The following is a description of a gene set: from publication Cui A, Huang T, Li S, Ma A, Pérez JL, Sander C, Keskin DB, Wu CJ, Fraenkel E, Hacohen N (PMID 38057668) Cytokines mediate cell-cell communication in the immune system and represent important therapeutic targets. A myriad of studies have highlighted their central role in immune function, yet we lack a global view of the cellular responses of each immune cell type to each cytokine. To address this gap, the authors created the Immune Dictionary, a compendium of single-cell transcriptomic profiles of more than 17 immune cell types in response to each of 86 cytokines (>1,400 cytokine-cell type combinations) in mouse lymph nodes in vivo. A cytokine-centric view of the dictionary revealed that most cytokines induce highly cell-type-specific responses. For example, the inflammatory cytokine interleukin-1β induces distinct gene programmes in almost every cell type. A cell-type-centric view of the dictionary identified more than 66 cytokine-driven cellular polarization states across immune cell types, including previously uncharacterized states such as an interleukin-18-induced polyfunctional natural killer cell state. Mouse Gene Set: CUI_T_CELL_CD8_IL21_RESPONSE_UP species: Mus musculus Genes positively differentially expressed in cell type: CD8+ T cell upon treatment with cytokine: IL-21 in mouse lymph nodes in vivo., and this is the list of marker genes: Plac8, Eif2s2, Eif4a1, Hopx (NCBI Gene Id 74318), Hspd1, Nhp2, Psmb6, Anp32b, Igfbp4, Psme2, Nme1, Isg15, Nkg7, Rexo2, Phgdh, Ptma, Nop58, Dkc1, Prdx1, Pebp1, Pa2g4, Ddx39a, Ldha, Mif, C1qbp, Eif1, Hsp90aa1, Fbl, Ran, Cct5, Tuba4a, Pgam1, Ppp1r14b, Nop56, Srm, Hspa8, Psmb5, Snrpd1, Cct3, Ranbp1, Tuba1b, Psmb10, Npm3, Eif2s1, Socs3, Ncl, Ly6a, Psma7, Ppa1, Slc25a5 (NCBI Gene Id 11740), Eif5a, Atp5mc1, Srsf7, Tubb4b